The following is a description of a gene set: Any process that stops, prevents or reduces the frequency, rate or extent of complement-dependent cytotoxicity. Mouse Gene Set: GOBP_NEGATIVE_REGULATION_OF_COMPLEMENT_DEPENDENT_CYTOTOXICITY species: Mus musculus, and this is the list of marker genes: Cd59a, Il4, Hsp90ab1, Cd59b, Il13